The following is a description of a gene set: Mouse Gene Set: GOBP_POSITIVE_REGULATION_OF_DENDRITIC_SPINE_DEVELOPMENT species: Mus musculus Any process that increases the rate, frequency, or extent of dendritic spine development, the process whose specific outcome is the progression of the dendritic spine over time, from its formation to the mature structure., and this is the list of marker genes: Fmr1, Bhlhb9, Mfn2, Arf1, Hnrnpk, Dbnl, Cpeb3, D16Ertd472e, Eef2k, Crebbp, Zmynd8, Nlgn3, Ptprd (protein tyrosine phosphatase receptor type D), Pafah1b1, Psen1, Dlg5, Reln, Pak3, Foxo6, Caprin2, Itpka, Shank3, Grn, Afdn, Il1rapl1, Shank1, Cux2, Mtor, Dhx36, Camk1, Llph, Eif4g2, Ppp1r9a, Dnm1l, Baiap2, Actr3, Neurl1a, Stau2, Mapkapk5, Nlgn2, Xlr3b, Tiam1, Nlgn1, Lrp8, Pbrm1, Lpar1, Rac1 (NCBI Gene Id 52352), Cdkl5, Cask, Palm, Mecp2, Marcks, Cfl1, Il2, Dbn1, Slc30a1, Actr2, Camk2b, Opa1, Kalrn (NCBI Gene Id 72378), Caprin1, Ephb2, Nr3c1, Apoe, Mapk6, Itsn1, Mfn1, Tsc2